Given this list of marker genes Taf1c, Taf1, Ubtf, Rrn3, Ubtfl1, here is a description of the gene set: studied in species Mus musculus Mouse Gene Set: GOMF_RNA_POLYMERASE_I_GENERAL_TRANSCRIPTION_INITIATION_FACTOR_ACTIVITY A general transcription initiation factor activity that contributes to transcription start site selection and transcription initiation of genes transcribed by RNA polymerase I. Factors required for RNA polymerase I transcription initiation include upstream activation factor (UAF), core factor (CF), TATA binding protein (TBP) and RRN3. In all species characterized, RNA polymerase I transcribes a large polycistronic transcript that is processed into several mature rRNAs (3 or 4 depending on the species), including the large subunit rRNA (28S in humans), the small subunit rRNA (18S in humans), as well as one or two additional smaller rRNAs (the 5.8S rRNA in humans). In most species, this large rRNA transcript is the sole product of RNA polymerase I. However there are rare exceptions, such as Trypanosoma brucei, where RNA polymerase I also transcribes certain mRNAs.